Given this list of marker genes ATG9A, SERINC2 (serine incorporator 2), ANO4, TMEM41B, XKR8, VDAC2, ANO9, TMEM63B, P2RX7, PLSCR3, PLSCR1, FASLG, CLPTM1L, XKR9, ANO3, SERINC3, ATG9B, XKR6, PLSCR5, ANO7, TRPC5, ANO6, VMP1 (vacuole membrane protein 1), XKR7, PLSCR4 (phospholipid scramblase 4), SLC4A1, SERINC5, XRCC4, XKR4, PLSCR2, here is a description of the gene set: species: Homo sapiens Human Gene Set: GOBP_PLASMA_MEMBRANE_PHOSPHOLIPID_SCRAMBLING The movement of a population of phospholipid molecules from one leaflet of the plasma membrane bilayer to the opposite leaflet, resulting in loss of lipid asymmetry and surface exposure of phosphatidylserine (PS) and phosphatidylethanolamine (PE).